Given this list of marker genes ANGPTL2, ZC3H12C, PGAM1, NFKBIZ, MLLT11, BIRC2, TMEM11, KIN, ZFP36L1, ENO2, CCR1, S100A3, SFPQ, TARS1, ATXN7L3B, U2SURP, DDX54, WBP1, CISH, NPTX1, ATF3, TAF1D, RELB (RELB proto-oncogene, NF-kB subunit), GCH1 (GTP cyclohydrolase 1), MAFK, BCL10, CFLAR, NABP1, SH2D2A, TGIF2, SLA, PI4KA, HK2, WSB1, HLA-DMA, SRSF5, BMP7 (NCBI Gene Id 655), ZFP36, BTG2, BHLHE40, FGF13, ZFAND5 (NCBI Gene Id 7763), CSNK1D, ANLN, MAP3K3, PHC2, JMJD6, DUSP1 (NCBI Gene Id 1843), CLK3, AMY2A, TUT7, IRF1, ERO1A, ERRFI1, CSF1, SLC25A25, GTF2E2, IL4 (NCBI Gene Id 3565), CCL4, ULK1, SMARCD1, NAB2, JUNB, FOXF2, NFIL3, MT1E, ST7, BLTP2, KLF5, PLK3, ZNF703, GEM, EGR2, BCL2A1, PRDM1, SYT3, NDRG1, DNAJB9, TIPARP, PCNT, CTLA4, SOCS3, HCFC1, ZFHX3, YTHDC1, CAPN1, ITPKB, MAP3K8, RBM38, CITED2, ADORA2B, ME1, AREG, NFKBIA, MYC, ADGRB1, SMIM7, PTPN22, NCAPH, SEC23IP, MAT2A (NCBI Gene Id 4144), FOS, MAK, TBCEL, ITK, LYST, FOSL1, FASTKD5, LDLR, RSAD2, TGIF1, CXCR4, IER2, IFITM10, RNFT1, PPP1R15B, TRAF3IP2, KCTD12 (potassium channel tetramerization domain containing 12), DNAJB1, SLC2A1, RRS1, F2R, RHOB, CCL13, RRAD, MYO10, NDEL1, SLC6A15, MAPK6, ATP5MF, SNIP1, FURIN, CSTF2T, NR4A1, MBD1, ETS2, NAMPT, CLP1, MZT2B, PHETA1, NFATC1, SQLE (squalene epoxidase), IFIH1, TPMT, SLC41A1, ERF, ARID3B, EIF1AY, PELI1, TOR1AIP2, MKNK1, LHX1, TENT5A, B3GALT2, EVI2A, SGK1, MDFIC, DLG4, GPR65, PHLDA1, RMDN3, CCL7, MTF1, CCR8, TRIB3, SOS1, PRKCH, ALDH18A1, MPRIP, KLF6, CYB5R3, TLK2, ZNF622, MATN4, MUC1, H2AX, AMBRA1, IER3, EGR1, SLC38A2, IL13, SERTAD1, CLK1, DUSP6, AMZ2, TNFSF9, IRS2, KAT2B, EIF1, NEDD9, PPP1R15A, UBE2Z, IL10, TNF, MED10, BTG1, USP38, MARCO, IL6, P4HA1, here is a description of the gene set: Genes down-regulated in double positive thymocytes: wildtype versus TCF3 and TCF12 knockout. species: Homo sapiens We wanted to test the role of mammalian E proteins E2A and HEB in the development of T cells. Using a conditional deletion system in which these proteins are deleted at the DP stage of T cell development, we compared DP thymocytes deficient for E2A, HEB or both to wild-type thymocytes from publication D'Cruz LM, Knell J, Fujimoto JK, Goldrath AW (PMID 20154672) Human Gene Set: GSE19923_WT_VS_HEB_AND_E2A_KO_DP_THYMOCYTE_DN